The following is a description of a gene set: part of: Processive synthesis on the lagging strand electronically inferred by orthology from the curated human pathway studied in species Mus musculus Reactome Pathway: Removal of the Flap Intermediate This event has been computationally inferred from an event that has been demonstrated in another species.<p>The inference is based on the homology mapping from PANTHER. Briefly, reactions for which all involved PhysicalEntities (in input, output and catalyst) have a mapped orthologue/paralogue (for complexes at least 75% of components must have a mapping) are inferred to the other species., and this is the list of marker genes: Dna2, Pcna, Pold2, Pold4, Prim1, Pola2, Pold1, Rpa1, Pola1